The following is a description of a gene set: studied in species Homo sapiens A process in which a small Cajal body-specific RNA is transported to, or maintained in, a Cajal body. Human Gene Set: GOBP_SCARNA_LOCALIZATION_TO_CAJAL_BODY, and this is the list of marker genes: CCT4, CCT2, DKC1, WRAP53 (NCBI Gene Id 55135), TCP1